Given this list of marker genes Prkci, Ripk2, Ngf, Ubb, Uba52, Nfkb1, Ikbkb, Myd88, Sqstm1, Ngfr, Rps27a, Irak1, Ubc, Rela, Uba52rt, Traf6, Nfkbia, here is a description of the gene set: Mouse Gene Set: REACTOME_P75NTR_SIGNALS_VIA_NF_KB p75NTR signals via NF-kB studied in species Mus musculus